The following is a description of a gene set: Papillary cystadenoma of the epididymis studied in species Homo sapiens Human Gene Set: HP_PAPILLARY_CYSTADENOMA_OF_THE_EPIDIDYMIS A cystadenoma, an epithelial tumor, that originates within the head of the epididymis., and this is the list of marker genes: EP300, VHL, HNF1B, CREBBP, CCND1